The following is a description of a gene set: Human Gene Set: MORF_IL13 Neighborhood of IL13 species: Homo sapiens Neighborhood of IL13 interleukin 13 in the MORF expression compendium, and this is the list of marker genes: UBE4B (NCBI Gene Id 10277), KCNJ4, LPGAT1, CACNB2, GRIK5, WDR62, TNIK, ECE1, IL16, LRCH4, INPP5E, POFUT2, PPP2R5B, TNFRSF25, MSL3, NR2F1, CLPX, COLQ, CTRL, TSSK2, SLC18A1, WBP4, IKBKE, FLT1, SCAMP1, EXTL3, SLC2A1, TJP1, SYT5 (NCBI Gene Id 6861), ARHGEF12, POU6F2, ZBTB22, TFDP2, PSMF1, SSTR5, FUT6, HSD17B3, TAF5L, EPHB2, TBX19, ZNF292, PDE4A, LTBP4, SCAPER, CASP10, OSBP, GNPAT, DTX4 (NCBI Gene Id 23220), KIAA0586, RXRG, HTR1B, FRYL, S100A5, ECE2, SULT4A1, SLC30A3, AFF2, HOXA11, SLC16A5, PLEKHB1, TBX5 (NCBI Gene Id 6910), HTR3A, NF1, NCKIPSD, ESR1, FNTB, ADCY3, IRS2, MAGEA9, PIK3C2A, AANAT, HTR7, PPP1R1A, POLR2K, CYP2E1, CRHR1 (corticotropin releasing hormone receptor 1), MFN1, DKK4, RAP1A, IFT27, PARVB, SEZ6L, RUNX1, ATP6V0A2, BCL2, HOXD13, DRC3, SERPINA4, SLC24A1, NTPCR, AQP5, GPATCH8, RAP2C, CYP11A1, BRCA1, ZNF134, ELAVL2, TANC2, OPRL1, HCRT, SLC33A1, KRR1, UPK1A, RUNX2, CYP2D6, PIK3CB, IL11RA, FPR2, MC2R, TIE1, CCKAR, TMEM11, STK17A, GLE1, COL19A1, GPR15, DGCR5, GABRB2 (gamma-aminobutyric acid type A receptor subunit beta2), PVR, CXCR3, AGPS, PGM3, POLR3D, FIG4, MSH3, NPHP4, HOXD4 (NCBI Gene Id 50714), ZNF157, SLC22A6, SIM2, PSG1, SYNJ2, BMP10, MT4, DPT, IGKV7-3, KANK2, ZNF200, TUBGCP4, SPEF1, DOCK1, SLC6A11, UTRN, CD3E, ITIH3, ARL3, ZNF133, GTSE1, PRELID3A, MSX1, PAXIP1, SULT2B1, ZBTB14 (NCBI Gene Id 7541), TENM4, COX6A2, NRXN1, RAD51D, CDYL, TBC1D22A, LCOR, IRF2, CNKSR1, ITPR2, ABCB10, ZBTB40 (NCBI Gene Id 9923), PHLDB1, C1orf216, IVL, SLC4A3, NRP2, NRTN, LBP, JAG1, CACNB1, KRT2, ZNF710, NOS2, ZNF500, AQP7, GRIP2, BNIP1, ABCC8, ERCC4, CDC73, PIGR, KANK3, ZNF592, CELA2B, KRT86, AOC4P, IL13, CAMK2G, GJB5, ZNF266, P2RY10, ATRX, ASB4, FOSL1, CMA1, DNAJC16, ATP6V1B1, KRT33A, KLHL18, PAX9, PIGB, POU6F1, NR2C1, ERC1, SGCD, ACACB, MYOZ3, CD6, RBBP8, SGPL1, ABO, HNF1A, PHF10, NR1I2, ITIH4, BRD1, GPR19, BAHD1, MC5R, NPFF, ENTREP1, RREB1, AMMECR1, TMEM94, PRKACA, GPR18, HTR4, ZP2, JRK, LY9